The following is a description of a gene set: species: Homo sapiens Human Gene Set: WP_10Q22Q23_COPY_NUMBER_VARIATION 10q22q23 copy number variation, and this is the list of marker genes: CCSER2, GHITM, NFKB1, DNAJB13, PDS5A, RSPH6A, DYDC1, BMP2, GRID1, LINC00858, RSPH4A, TNFSF11, ADAM10, BMPR1A, SMC3, GLUD1, RGR, IQUB, AFG3L2, MIR346, ROPN1L, ACTN2, OPN4, LRIT1, SHLD3, SIRT4, ZMYND11, LDB3 (NCBI Gene Id 1219), TSPAN14, SMC1A, PPARG, PRXL2A, DYDC2, RAD21, RSPH9, NRG3 (neuregulin 3), CEBPA, SHLD1, SHLD2, MAD2L2, GPR15LG, RSPH3, STAG1 (STAG1 cohesin complex component), RSPH1, SH3GL3, MMRN2, LRIT2, NME5, CDHR1, SUSD2, GPR15, MAT1A, PDS5B, ADIRF, SH2D4B, RSPH14, ERBB4, SF3B4 (NCBI Gene Id 171), BUB1B, FAM25A, SNCG, VEGFA, WAPL, MAS1